Given this list of marker genes SLC5A8, MPC1 (NCBI Gene Id 51660), MPC1L, SLC16A7, SLC16A11, SLC16A3, MPC2, SLC16A1, here is a description of the gene set: species: Homo sapiens Human Gene Set: GOBP_PYRUVATE_TRANSPORT The directed movement of pyruvate into, out of or within a cell, or between cells, by means of some agent such as a transporter or pore.